Given this list of marker genes Nfe2, Synb (syncytin b), Hey2, Rbpj, Akt1, Hs6st1, Plcd3, Ggnbp2, Esx1, Ncoa6, Wnt2, Hes1, Mapk1, Junb, Fzd5, Tmed2, Hey1, Vash1, Llgl2, Syde1 (NCBI Gene Id 71709), Fbxw8, Plg, Vash2, Ovol2 (NCBI Gene Id 69059), Plcd1, Ccn1, Nsdhl, here is a description of the gene set: studied in species Mus musculus The process whose specific outcome is the progression of a blood vessel of the labyrinthine layer of the placenta over time, from its formation to the mature structure. The embryonic vessels grow through the layer to come in close contact with the maternal blood supply. Mouse Gene Set: GOBP_LABYRINTHINE_LAYER_BLOOD_VESSEL_DEVELOPMENT